Given this list of marker genes ABCD1, here is a description of the gene set: Reactome Pathway: Defective ABCD1 causes ALD The 70-kDa peroxisomal membrane protein (PMP70) and the adrenoleukodystrophy protein (ALDP aka ABCD1) are half ATP binding cassette (ABC) transporters in the peroxisome membrane. They are involved in metabolic transport of long and very long chain fatty acids into peroxisomes. Mutations in the ALD gene result in the X-linked neurodegenerative disorder adrenoleukodystrophy (ALD; MIM:300100). ABCD1 deficiency impairs the peroxisomal beta-oxidation of very long-chain fatty acids (VLCFA) and facilitates their further chain elongation by ELOVL1 resulting in accumulation of VLCFA in plasma and tissues. While all patients with ALD have mutations in the ABCD1 gene, there is no general genotype-phenotype correlation. In addition to ABCD1, other genes and environmental factors determine clinical features of ALD. studied in species Homo sapiens part of: ABC transporter disorders